Given this list of marker genes CREB3L3, ALB, P4HB, LIPG, APOC3, APOE, CETP, CIDEC, PCSK5, ANGPTL3, PCSK6, LCAT, MBTPS2, ANGPTL4, MBTPS1, APOB, LMF2, LPA, APOF, APOA2, LPL, LIPC, ANGPTL8, APOA1, FGF21, GPIHBP1, APOA5, MTTP, APOC2, APOA4, LMF1, ABCG1, PLTP, FURIN, here is a description of the gene set: Human Gene Set: REACTOME_PLASMA_LIPOPROTEIN_REMODELING species: Homo sapiens Plasma lipoprotein remodeling